The following is a description of a gene set: Diphtheria is a serious, often fatal human disease associated with damage to many tissues. Bacteria in infected individuals, however, are typically confined to the lining of the throat or to a skin lesion; systemic effects are due to the secretion of an exotoxin encoded by a lysogenic bacteriophage. The toxin is encoded as a single polypeptide but is cleaved by host furin-like proteases to yield an aminoterminal fragment A and a carboxyterminal fragment B, linked by a disulfide bond. Toxin cleavage can occur when it first contacts the target cell surface, as annotated here, or as late as the point at which fragment A is released into the cytosol. Fragment B mediates toxin uptake into target cell endocytic vesicles, where acidification promotes a conformational change enabling fragment B to form a channel in the vesicle membrane through which fragment A is extruded into the target cell cytosol. Cleavage of the inter-fragment disulfide bond frees DT fragment A, which catalyzes ADP ribosylation of the translation elongation factor 2 (EEF2) in a target cell, thereby blocking protein synthesis. Neither fragment is toxic to human cells by itself. part of: Uptake and actions of bacterial toxins studied in species Homo sapiens Reactome Pathway: Uptake and function of diphtheria toxin, and this is the list of marker genes: HSP90AB1, HBEGF, HSP90AA1 (NCBI Gene Id 89272), TXNRD1 (NCBI Gene Id 7296, thioredoxin reductase 1), CD9, EEF2